The following is a description of a gene set: species: Homo sapiens Any process that modulates the frequency, rate or extent of the chemical reactions and pathways resulting in the breakdown of a protein by the destruction of the native, active configuration, with or without the hydrolysis of peptide bonds. Human Gene Set: GOBP_REGULATION_OF_PROTEIN_CATABOLIC_PROCESS, and this is the list of marker genes: RNF128, PITHD1, NEURL3, SOX17, USP25, KCNE2, SUMO2, ALAD, UBQLN2, LRP1, NEDD4, CENATAC, NUDT15, LPCAT1, TMEM259, ZFAND2A, VPS28, OAZ1, MGAT3, RNF41, AKT1, ATXN3, DNAJB2, STUB1, PSMD1, N4BP1, PKD1, DAB2, TMEM132A, NFE2L2, NUB1, GGA1, TRIM39, PSMC1, COMMD1, SUMO1, GRIN2A, FOXF2, PACSIN3, TNFRSF1B, FBXO2 (NCBI Gene Id 4930), AMER1, RCHY1, SH3RF2, GBA1, RNF185, TIMP3, PTPN3, CAV1, HERPUD1, FYN (NCBI Gene Id 2534), DTL, EEF1A2, OAZ2, C4BPB, CCAR2, OPHN1, CDH1, AURKA, MIR128-1, ATXN3L, RYBP, AQP11, TSPAN5, TRIB3 (NCBI Gene Id 57761), PSME3, USP8, LRRK2, PSMC2, ARAF, UFL1, SOX9, RIC1, MYLIP, MARCHF7, RDX, GPC3, RBX1, ZDHHC2, IL33, NSF, UBQLN1, LAMP3, ITCH, PRKN, GIPC1, TAF9, SNX33, PCSK9, MFSD8, USP9X, NKD1, CTSA, BAG6, ADRA2A, PSMC4, CYP51A1, CST3, CSNK2A1, ZYG11B, CREBRF (NCBI Gene Id 153222), NDFIP1, SNX1, PLK2, NFE2L1, AXIN2, CD81, HECTD1, OGT, AXIN1, SF3B3, TF, TRIB1, GSK3B, VIP, ANXA2, GABARAP, ODC1, CHEK2, USP38, DDB1, SMARCC1, LRIG2, TMF1, SH3D19, SHH, ROCK1, SIRT2, CBFA2T3 (CBFA2/RUNX1 partner transcriptional co-repressor 3), FAM83D, RAB7A, IFNG, AZIN2, BAG5, PSMD14, NOP53, NEDD4L, MDM2, PSMC5, RAD23A, FMN2, CLU, TTC36, RAD23B, NKD2, CSNK1E, RHBDD3, UBQLN4, SMAD4, TSPAN15, CSNK2A3, AGAP2, ECSCR, SEC22B, RPL11, F8A3, DNAAF4, PRKCG, TAF1, WDR91, ATRAID, INS (NCBI Gene Id 3630), TNFSF12, PLK1, HAMP, NOS2, PRICKLE1, TRIM40, DAOA, FBXW7, STX5, HSP90AB1, TMTC3, UBR3, HSPA1A, FBXW8, PARK7, SOCS5, SERPINB12, RNF180, WFS1, STYX, NUPR1, EZR, TNF, PSMC6, GPLD1, PSME1, USP13, MAD2L1, TMEM9, ZER1, SNRNP70, UBXN1, EGFR, CHFR, CAMLG, FBXO22, CUL4B, GLMN, TREM2, DAB2IP, ZNF268, CSNK1D, EGLN2, ADAM9, TIMP4, KEAP1, DDRGK1, TIPARP (NCBI Gene Id 25976), DCAF1, CHMP6, UBQLN3, IL10, SH3RF1, CEBPA, SNF8, ELOB, PLK3, BARD1, COP1, PSMC3, PHF20L1, RHBDF1, MTM1 (myotubularin 1), PIAS1, VPS35, FOXO1, F8A2, SIRT6, TSPAN17, USP14 (ubiquitin specific peptidase 14), CSNK1A1 (NCBI Gene Id 55416), XPO1, EEF1A1, ABCA2, ASB5, SENP1, RELA, DESI1, MAP1A, SGTA, ADAM8, UCHL5, MIR181B1 (microRNA 181b-1), ZNF418, XBP1, LRP2, OSBPL7, PIN1, WAC, NQO1, CDK5RAP3, GCLC, CBLB, TIMP2, PSME2, SNX3, SORL1, USP5, TIMP1, PPP2R3A, TRIM32, PBK, FAF1, GRIN2C, SMAD3, PSME3IP1, GNA12, SVIP, GPX1, MAD2L2, EIF3H, TMX1, LAPTM4B, GFAP, FMR1, USP26, OAZ3, EPM2A, IDE, CSNK2B, ATP13A2, VCP, PSMF1, WNT10B, MYCBP2, NELL1 (NCBI Gene Id 4745), TRIB2 (tribbles pseudokinase 2), PABPN1L, SERPINE2, CDC20B (NCBI Gene Id 166979), HSPA1B, PRKACA, ARHGAP5-AS1, CSNK2A2, CDC20, PSMD10, BTRC, BBS7, F8A1, FBXL5, SNCA, USP7 (NCBI Gene Id 7874), IL1B, HSP90AA1, FURIN, IER3, UBB, SIRT1, UBXN2A, RFPL1, BAG2, FHIT, MAPK9, SGSM3, GGA3, RNFT1, HFE, GSK3A, TLK2, C4BPA, VGLL4, USP19, SNX9, PSMD2, TNFAIP3, ATG7, PINK1, APP, FZR1, MARCHF2, RGMA, RILP, UBE2K, RNFT2, HMGCR, PSMD3, AZIN1, DACT1, RHBDD1, CDK2, MSN, FLNA, MDM4 (NCBI Gene Id 4194), CDKN1B, ASB9, PHB1, SMAD7, ASB11, DEDD, PAQR3, SOCS4, GABARAPL2, APOE, DDA1, NRDC, CUL4A, ADGRB1, HSPBP1 (NCBI Gene Id 29987), SH3RF3, PABIR1, WNT5A, HGS, IRAK3, VPS11, SNX12, APC, DVL1, NDUFA13, BCAP31, PANO1, LDLR, PSEN1, FBXL20, KLHL40, RACK1, DET1, RGP1